The following is a description of a gene set: Human Gene Set: MIR3688_3P from publication Chen Y, Wang X (PMID 31504780) studied in species Homo sapiens Genes predicted to be targets of miRBase v22 microRNA hsa-miR-3688-3p in miRDB v6.0 with MirTarget v4 prediction scores > 80 (high confidence targets)., and this is the list of marker genes: PLEKHF2, SEPTIN14 (NCBI Gene Id 378074), SLC2A12, CD93, GLIS3, AK3, LATS1, ARHGEF9, TRIM50, ACER3, YPEL5, PEG3, PDZD8, RAC1, MIER1, DPF3, B4GALT5, CAMK1, EFNB3, TMF1, HDLBP, ZNF257, ZFP82 (NCBI Gene Id 284406), EFCAB5, SPIRE1, CCT2 (chaperonin containing TCP1 subunit 2), SKIL, DOCK7, KBTBD8, RASGEF1B, OAZ2, MTARC1, ADAM30, C9orf40, ITGA9, UEVLD, PANK1, LHX8, PPP1R18, MPC1, GPR161, ADAMTS17, NAPEPLD, ZMYM2, TUBA1B, COX20, PPP4R3B, AGGF1, PIAS1, CSRNP1, TENM3, NFATC2, PCSK5, SRGAP2C, LDB2, MOAP1, LINC02694, USP2, KCTD18, DPEP2NB, WAPL, CAMKK2, TMEM178B, GBP3, ZC2HC1A, RTL8B (retrotransposon Gag like 8B), RSAD2, FRMD3, RIT1, ATP2B4, RBBP9, WDR31, DCHS2 (dachsous cadherin-related 2), JADE3 (jade family PHD finger 3), ZNF131, EPGN, VDAC2, DCAF4L2, SMC5, HOXA10, MON2, UFL1, POC5, FILIP1L, CECR2, MRTFB, LEPROTL1, PDK1, CNOT6L, SPATA4, MEF2C, MROH5, SLC2A3, CD300LD-AS1, MIGA1, MYH10, SESN3, RTKN2, GABPA, SAFB2, OTUD7A, CDH13, IMPACT, GALNT13, UACA (uveal autoantigen with coiled-coil domains and ankyrin repeats), STOM, GLIPR1, ENTPD7, IGF1, TLCD4, SLC6A8, TM9SF3, POGLUT3, SH3TC2 (SH3 domain and tetratricopeptide repeats 2), G3BP2, IL1R1, STAG2, ERMN (ermin), MBOAT4 (membrane bound O-acyltransferase domain containing 4), RSBN1L (round spermatid basic protein 1 like), KCTD9, RANBP9, SLC2A14, CHIC1, COL21A1, DCUN1D2, FRMD4B, TMEM26, NEU3, STK17B, LMOD1, COL4A4, PLAG1, ACSL4, FCHO2, DSC2, SHC1, MAP2, INPP5E, MAP4, IFT81, DLGAP1 (NCBI Gene Id 9229), RNF39, SBSPON, KDM1B, DCDC1, PCDH15, MYSM1, BMPR2, CCL28, GFRA1, ZFAND6, SGPP1, LRAT, KPNA1, HDDC2, UGT2A1, AMOT, NGLY1, BLOC1S2, TUT4, RDH8, SMARCA2, PTPRS, ZNF366, RAB27B, UBE2V1, EIF5A2, SHE, SERINC3, ZC3H12C, PNISR, MT1A (metallothionein 1A), PLXNA4, DCBLD2, UBE2D2, GRM1, HNRNPK, POFUT2, FMR1, CCDC102B, OGFOD1, UGT2A2, NEUROD4, C1orf21, TACC1, ELK4, MIA3, PHYHIPL, ERAP2, PCDH10, MSH2, ZNF681, B3GNT5, CCDC169, TINAG, TLCD5, ARL15, SORCS1 (sortilin related VPS10 domain containing receptor 1), PPP1CC, PCDH18, MAGI1, UBL3, NEDD4L, CHM, ELL2, PRRC2C, C10orf90, PELI2, ADCY9 (NCBI Gene Id 115), ZNF704, SMARCAD1, KHDRBS3, CSNK2A2, EPC2, PPIP5K2, PDK3, NUDT11, ADAM7, IMP4, IKZF2, ZIC1, KRAS, NAIP, IGSF11, MED12L (NCBI Gene Id 57726), KCNE4, ZNF664, SMNDC1, LANCL1, EXOC5, BRMS1L, JAK2, TK2, LSAMP, PRDX1, CAPZB, PGAM1, TMEM182, AP1G1, CETN1, DKK3, POF1B, ATRX, CCDC126, DYNC1I2, NTRK2, ABI1, CCL20, ATXN3, GRK6 (G protein-coupled receptor kinase 6), SVEP1, NAA30, JMJD1C, ADAM22, APBB2, DESI2 (NCBI Gene Id 51029), COG5, PBK, TLR3, PSMD12, SENP2, ABCC12, LHFPL2, RAB33A, GDAP1, GRIA2, INO80D, DCLK1, ROCK2, FOS, CCSER1, MBNL3, HNRNPU, CHMP5, RETREG2, FGF12, SRSF10, NFYC, SAMD7, ATP10B, NR6A1, CREB1, DNAJC21, GUCY1A2, TGIF1 (NCBI Gene Id 91941), CTCF, TJP2, CCDC25, CCAR2, SAMD9L, CLCN5 (NCBI Gene Id 90056), LIN9 (NCBI Gene Id 286826), NUFIP2, RCN2, KHSRP, ZFYVE28 (NCBI Gene Id 57732), RANBP1, TM9SF2, VAV3, PPDPFL, ARPIN, LRRTM4, ARB2A, PLPPR5, ATXN1, C2CD4A (C2 calcium dependent domain containing 4A), KRT6C, PRKAA1, UBR2, LUC7L, VAMP4, SRSF3, RIMS2, SEPTIN8, IDI2, SLC8A1, DHX35, TCEA1, GEN1, TGFA, GPR15, PCTP, TRAF3IP1, MINAR1, PEDS1-UBE2V1, SIRT1, TMEM38B, ZNF827, GNB2, HTR1F, CCDC6, ZNF519, SELENOP (NCBI Gene Id 6414), ADAMTS1, CAND1, ADAMTS3, API5, MPLKIP, XPO4, ATP13A3, CD80, SWSAP1, NHSL3 (NHS like 3), DTD2, ZFHX3, SOX30, HIGD1A, FAR1, WDR26, MMRN1, OTUD1, TNFRSF19, ARID4B, CYP17A1, LHX4, HOMER1, SH3BP5, RORA, SIKE1, LTBP4, PRRC2B, ATXN2, TEDDM1, LGI1 (NCBI Gene Id 9211), ATP6V1G1, FAM98B, UBE3A, CCDC88A, CXXC4, SEC23A, KCNIP4, COG2, FOXP1, GNAI3, GLS, FAM76A, CCBE1, PDK2, SEPTIN7, ZNF772, CFL2, MAP1B, ATP2B2, ABCA1, GNAQ, RNF2, DSG1, PRICKLE2 (prickle planar cell polarity protein 2), SYT9, POLR2K, OSBPL3, FOXF1, DIPK1B, ZNF180, MAGI2, RAB1A, LPP, VPS26A, APOBEC3H, ZBTB21, NPY1R, SCLT1, IL22, SLC23A2, PCNX1, FAM120B, PAK2, LRP12, DYNLT1, RIOK3, HSPE1 (heat shock protein family E (Hsp10) member 1), ESYT3, SHOC2, RBM45 (NCBI Gene Id 129831), HNMT